Given this list of marker genes FOXA3, XPO6, INO80D, PIGC, SMOC1, NFAT5, CCDC107, CYLD, FOXJ2, SNAP25, BMF, DNAJA1, CDK6, SESN2 (sestrin 2), EPHB6, TRIB2, TAL1, GPHN, DUSP22, LINC01138, PPP2R5E, ALKBH6, AKR1B1, IL1RN, ARPC5, MAP3K13, CCN2, JPH3, SOX3, GRK5, COL11A2, MRPS6, RND1, EIF5A, TFE3, LUC7L3, PTGR3, ITGB8, HOXB9, ECT2 (NCBI Gene Id 55710), PTGES, NOTUM, ZNF821, RIN2, PAPPA, LCAT (NCBI Gene Id 3931), BCL3, CLCN1, YY1AP1, GADD45B, PLA1A, SCRT2, RANBP10, ARHGAP44, RAP2C, CDC37, ENO3, TOP1, CCDC8, ARHGEF2, RSF1, FOXD3, SOX5, SNX15, RAB10, FOS, LAMB3, PCSK2, BDNF, BAHD1, EGR3, PTCHD1, IER5, MLLT6, S1PR2, VSX2, LASP1, FAM117A (family with sequence similarity 117 member A), SEMA3B, PTHLH, SLC43A1, NFKBIB, ZNF436, FUT7, TNIP1, TNFSF18 (NCBI Gene Id 8995), MIDEAS, APPL1, PHF6, FTHL17, IL13, S100A10, SEC14L2, KANSL3, DACH2, JAK3, MIR17HG, ASCL3, FOXD2, IL27RA, IL27, NOS2, ANP32A, ADGRB2, EFNA3, CCL22, SP6, NPAS4, STX4, TSLP, CXCL10, PPP3CA, GPBP1, SIRT2, IL18R1, LYPLA2, DDR1, NDRG2, RALGDS, PURG, DCLK1, RFTN2, ANKHD1, IL2RA, LRCH1, AMOTL1, ARHGAP8, ZNF384, ITGB4, PTGS2, ICAM1, AAMDC, PTMS, IL1A, ZNF436-AS1, SH2B3, DDX17, MAG, UACA, TP63, HSP90B1, SMPD3, CTAGE4, PTPRJ, TMEM88, SLC6A12, IL1RAPL1, EGR2, UBE2I, SIX5 (NCBI Gene Id 1754), WRN, HHATL, LTB, LIN28A, C1QL1, GNAO1 (NCBI Gene Id 2775), SIN3A, TCTA, SMARCAD1, OPCML, MYO18A (myosin XVIIIA), HOXA11, TCEA2, IL4I1, SLAMF8, BCKDK, SYMPK, EGF (epidermal growth factor), IL23A, ACAP3 (ArfGAP with coiled-coil, ankyrin repeat and PH domains 3), PFN1, PNKD, ALG6, MSX1, ARHGAP5, VEZF1, VNN3P, ID2, PCBP4, GNA13, CD40, RORC, IRF1, LCN2, MNT, STAT6, CARTPT, PLP1, NFKBIA, ZHX2, GDPD5, CCL5, PAN2, ZNF800, TINAGL1, KCNT2, CGGBP1, ASH1L, CHD4, CUEDC1, IFNB1, TJAP1, GABPB2, EHF, HOXB6, RGL1, G3BP1, LIX1L, HSD3B7 (hydroxy-delta-5-steroid dehydrogenase, 3 beta- and steroid delta-isomerase 7), SOBP, DAP3, NUP153, RAD18, NFKB2, CDC14A, EBF1, SCAF4, BCL2L1, PARP8, ACAN, CYB5A, CD247, PPP1R13B, IL2, TASL, TAFAZZIN, TYRO3, MSC, ZNF217, CD70, TNR, FAM241A, LRRFIP2, FGF17, FLI1, FGF1, RHOA, PHF20, PRKCD, GNG4, TNIP3, GRIN2D, MAML2, MOB3C, CDH5, NLK, SLC34A3, VCAM1, SUN2, HCFC1, SPTB, CA9, TSNAXIP1, SOCS2, CXCR5, RHOG, NOS1AP, ANKHD1-EIF4EBP3, CD74, BHLHE40, GATA4, KCNQ5, TRIM47, SOX10, MAP3K8, BCL11A, WNT10A, TNFSF15, here is a description of the gene set: Genes having at least one occurrence of the motif NGGGACTTTCCA in the regions spanning 4 kb centered on their transcription starting sites. This matches the transcription factor binding site V$NFKB_C (v7.4 TRANSFAC). studied in species Homo sapiens Human Gene Set: NFKB_C